Given this list of marker genes Fgf13 (NCBI Gene Id 14168), Irgm2, Ubqln4, Map1a, Tmod3, Tbc1d25, Plekhh2, Zmpste24, Gsn, Scaf8, Sptb, Oga, Clasp1, Shroom2, F2rl1, Shfl, Setx, Per2, Tmod4, Dstn, Camsap1, Carmil2, Eps8, Flii, Map2, Ckap2, Upf1, Atg5, Cln3, Gspt1, Igf1r, Asph, Bnip3, Camsap3, Ttbk2, Nav3, Apc2, Irgm1 (immunity-related GTPase family M member 1), Tecpr1, Evl, Tpm1, Mtpn, Avil, Clasp2 (CLIP associating protein 2), Trpv4, Tom1, Ogfod1, Lmod2, Phf23, Twf1, Wnk1, Mid1ip1, Capza1, Capzb, Arpc2, Katnb1, Swap70, Rp1, Tmod1, Cfl1, Etf1, Hdac6, Add1, Atg12, Map1b, Vil1, Sh3bp1, Myh9, Tmod2, Capg, Twf2, Taok1, Arhgef2, Fyco1, Rubcn, Trim54, Svil, Htr1a, Gas2l1, Dmtn, Actn2, Eif5a, Dbnl, Eif5a2, Add2, Aurkb, Igtp, Camsap2 (calmodulin regulated spectrin-associated protein family, member 2), Sptbn1, Gas2l2, Lima1, Cib1, Stmn2, Jmjd4, Pdxp, Wdr1, Add3, Wdr47, Kif21a, Spta1, Spast, Vill, Smcr8, Insr, Calcoco2, Diaph3, Clec16a, Scaf4, Sema5a, Plek, Rdx, Tnf, Mid1, Ccdc88c, Eml4, Hdgfl3, Map1s, Specc1l, Bbof1, Lmod3, Map6d1, Nes, Atxn7, Cfl2, Tpx2, Capza1b, Lmod1, Pik3ca, Cracd, Gba1, Tmem39a, Capza3, Adrb2, Sptan1, Carmil1, Capza2, Apc, Bmerb1, Scin, Irak3, Spef1, here is a description of the gene set: studied in species Mus musculus Any process that modulates the frequency, rate or extent of protein complex disassembly, the disaggregation of a protein complex into its constituent components. Mouse Gene Set: GOBP_REGULATION_OF_PROTEIN_CONTAINING_COMPLEX_DISASSEMBLY